Given this list of marker genes STMN1, HSPA8, KLC1, RSPO1, MXRA7, NNAT, TGFBI, PRRX1, SUMO3 (small ubiquitin like modifier 3), RIMKLA, ELAVL3, AMPH, PRPH, BASP1, GAP43, CALCA, CXCL12, ST3GAL2, TUBB3, HIC1, HMGA2, NUAK1, MTCH1, TAGLN3, GNA14, FXYD6, HTR3B, ZWINT, COL8A1, SYT4, PRMT1 (protein arginine methyltransferase 1), KPNA2, CRMP1, ELAVL4, SPON2, RASA3, INHBA, AMHR2 (NCBI Gene Id 269), LYPD1, IGFBP4, PCDH8, CHD3, CALCB, NSG2, LIX1, RFLNA, OLFM1, HMX1, ENC1, TUBA4A, TUBA1B, NTRK2, TUBA3D, PLAT, here is a description of the gene set: studied in species Mus musculus Cancer cells differentiate along specific lineages that largely determine their clinical and biologic behavior. Distinct cancer phenotypes from different cells and organs likely result from unique gene expression repertoires established in the embryo and maintained after malignant transformation. We used comprehensive gene expression analysis to examine this concept in the prostate, an organ with a tractable developmental program and a high propensity for cancer. We focused on gene expression in the murine prostate rudiment at three time points during the first 48 h of exposure to androgen, which initiates proliferation and invasion of prostate epithelial buds into surrounding urogenital sinus mesenchyme. Here, we show that androgen exposure regulates genes previously implicated in prostate carcinogenesis comprising pathways for the phosphatase and tensin homolog (PTEN), fibroblast growth factor (FGF)/mitogen-activated protein kinase (MAPK), and Wnt signaling along with cellular programs regulating such 'hallmarks' of cancer as angiogenesis, apoptosis, migration and proliferation. We found statistically significant evidence for novel androgen-induced gene regulation events that establish and/or maintain prostate cell fate. These include modulation of gene expression through microRNAs, expression of specific transcription factors, and regulation of their predicted targets. By querying public gene expression databases from other tissues, we found that rather than generally characterizing androgen exposure or epithelial budding, the early prostate development program more closely resembles the program for human prostate cancer. Most importantly, early androgen-regulated genes and functional themes associated with prostate development were highly enriched in contrasts between increasingly lethal forms of prostate cancer, confirming a 'reactivation' of embryonic pathways for proliferation and invasion in prostate cancer progression. Among the genes with the most significant links to the development and cancer, we highlight coordinate induction of the transcription factor Sox9 and suppression of the proapoptotic phospholipid-binding protein Annexin A1 that link early prostate development to early prostate carcinogenesis. These results credential early prostate development as a reliable and valid model system for the investigation of genes and pathways that drive prostate cancer. Genes down-regulated in the urogenital sinus (UGS) of day E16 females exposed to the androgen dihydrotestosterone for 12 h. Human Gene Set: SCHAEFFER_PROSTATE_DEVELOPMENT_12HR_DN from publication Schaeffer EM, Marchionni L, Huang Z, Simons B, Blackman A, Yu W, Parmigiani G, Berman DM (PMID 18794802)